The following is a description of a gene set: species: Mus musculus Any process that modulates the frequency, rate or extent of type B pancreatic cell proliferation. Mouse Gene Set: GOBP_REGULATION_OF_TYPE_B_PANCREATIC_CELL_PROLIFERATION, and this is the list of marker genes: Nr4a1, Pdx1, Nr4a3, Nupr1, Ptprn, Irs2, Igf1, Wdr13, Reg1, Phip, Nr1d1, Sfrp1, Errfi1, Fmc1, Birc5 (NCBI Gene Id 11799), Men1, Sgpp2, Wnt3a, Phox2b, Cdk4